The following is a description of a gene set: studied in species Homo sapiens Human Gene Set: REACTOME_TRANSLOCATION_OF_SLC2A4_GLUT4_TO_THE_PLASMA_MEMBRANE Translocation of SLC2A4 (GLUT4) to the plasma membrane, and this is the list of marker genes: TUBA8, TUBB4A, TUBB6, EXOC8, SLC2A4, VAMP2, YWHAB, EXOC7, ACTB, TUBA4A, EXOC4, EXOC1, RAB4A, EXOC3, TUBA3C, ACTG1, MYH9 (myosin heavy chain 9), RALA, RALGAPA2, EXOC2, PRKAG3, ASPSCR1, TUBB8, YWHAZ, STXBP3, TUBB1, YWHAG, RAB11A, EXOC6, YWHAE, RHOQ, AKT1, TUBA3D, TUBB2B, RAB8A, YWHAH, STX4, SNAP23, AKT2, TUBB4B, KIF3A (NCBI Gene Id 11127), TUBA4B, TUBA1C, TUBB3, RAB10, TUBB2A, LNPEP, PRKAG1, PRKAA2, RAC1, TBC1D1, C2CD5, PRKAB2, KIF3B, RAB13, TUBB8B, KIFAP3 (kinesin associated protein 3), TUBA1A (NCBI Gene Id 95407), RALGAPB, TUBA1B, YWHAQ, RAB14, CALM1, SFN, TUBAL3, EXOC5, PRKAB1, MYO1C, PRKAG2, TUBA3E, MYO5A, TBC1D4